Given this list of marker genes IMP4, SEC24C, TNK2, MLLT6, ZNF490, HUWE1, MFAP1, KMT2E, FOXK1, RELA, CNOT6L, DDX46, TUG1, PPP6R3, ZC3H11A, ZFP36L2, ZNF770, HEATR1, PCNX3, LAIR1, SNRNP70, PRP4K, TARS1, GNA11, CTSW, KCTD12, CSK, RAPGEF6, PRPS1, RBM42, OLIG2, OTUD4, PAN2, AZI2, PRRC2B, PIK3CD, ELOVL7, NAT10, UFL1, SP1, NFIA, CHD3, SERPINB1, TSPO (translocator protein), MRPL47, LPAR6, CPSF1, BOD1L1 (biorientation of chromosomes in cell division 1 like 1), LGALS8, DDX18, WDR82, ZNF182, PYGO2, ZSCAN26, COQ2, DDX39B, ARHGEF12, CBX7, GAB3, UNK, LMBR1L, ZMYND11, ZKSCAN1, HIRA, IRS1, VPS28, SMPD1, SLC12A5, HGSNAT, RRAD, BIK, SZT2, NOP10, CEP164, IL16, RPL38, DEXI, NPB, KMT2D, LHFPL5, TUBA4A, GABRA2, ATP13A1, AP4E1, PACS1, CAMK1D, TMEM91, MEF2C (myocyte enhancer factor 2C), TTLL4, SGK1, LY6E, UBN1, C8orf58, RAI1, CFAP141, ZNF287, USPL1, CELF1, ZNHIT2, TECPR1, MBP, NTAN1, CD244, PLEKHM3, TAFAZZIN, PREX1, RNF123, NOLC1, PHF20L1, TBX6, ZMYM2, ST3GAL6, METTL17, PHF3 (NCBI Gene Id 23469), ATP8B1, HGH1, MS4A7, RASSF5, NOL9 (nucleolar protein 9), PTPN18, ASGR2, OSBPL7, TMEM64, PITPNC1, H6PD, CTCF, BLTP2, UBL3, GABBR1, FTX, KMT2C, BLTP1, SUN2, CLN3, ARHGAP45, FTH1, PNPLA7, KLHL26, MACROH2A1 (macroH2A.1 histone), TCIRG1, ZNF146, RABEP2, THY1, TOR1AIP1, DMTF1, ZFC3H1, EMG1, ZBTB4 (zinc finger and BTB domain containing 4), GAPVD1, MTCP1, KHNYN, MTFR1L, WDR5, SEPTIN6, DENND6B, AR, BBX, EXOSC1, MMP9, TRIM39, ALG1, PRPF8, ABHD8, SGSH, TK2, C2orf68, ARID2, MLYCD, MAST3, MYCBP2, SNAPC4, PRKACB, USP48, CRACDL, NCOA6, CST3, TOP2B (NCBI Gene Id 7155), VEZF1, COQ5, BCL11B, ATP2B4, ARHGAP5, TULP4, ARHGAP1, FYCO1, CCDC107, PWP2, TARS2, KRI1, SPNS1, PPP1R12A, MAT2A, MFSD6, RASA3 (NCBI Gene Id 22821), EMC1, PCNT, GGA3, TRAF3, G3BP2, PPP2R5A, here is a description of the gene set: Regulatory T (Treg) cells characterized by expression of the transcription factor forkhead box P3 (Foxp3) maintain immune homeostasis by suppressing self-destructive immune responses1-4. Foxp3 operates as a late acting differentiation factor controlling Treg cell homeostasis and function5, whereas the early Treg cell lineage commitment is regulated by the Akt kinase and the forkhead box O (Foxo) family of transcription factors6-10. However, whether Foxo proteins act beyond the Treg cell commitment stage to control Treg cell homeostasis and function remains largely unexplored. Here we show that Foxo1 is a pivotal regulator of Treg cell function. Treg cells express high amounts of Foxo1, and display reduced T-cell receptor-induced Akt activation, Foxo1 phosphorylation, and Foxo1 nuclear exclusion. Mice with Treg cell-specific deletion of Foxo1 develop a fatal inflammatory disorder similar in severity to Foxp3-deficient mice, but without the loss of Treg cells. Genome-wide analysis of Foxo1 binding sites reveals ~300 Foxo1-bound target genes, including the proinflammatory cytokine Ifng, that do not appear to be directly regulated by Foxp3. These findings demonstrate that the evolutionarily ancient Akt-Foxo1 signaling module controls a novel genetic program indispensable for Treg cell function. from publication Ouyang W, Liao W, Luo CT, Yin N, Huse M, Kim MV, Peng M, Chan P, Ma Q, Mo Y, Meijer D, Zhao K, Rudensky AY, Atwal G, Zhang MQ, Li MO (PMID 23135404) species: Homo sapiens Genes up-regulated in normal T reg (nTreg): FOXO1 versus wildtype. Human Gene Set: GSE40655_FOXO1_KO_VS_WT_NTREG_UP